Given this list of marker genes LSMEM1, SKA1, HYCC1, SSRP1, EOMES, SLC44A5, DCUN1D5, BCAM, PATE4, FOXJ3, ARL17A, TMEM260, JPH1, RORA, GSK3B, TRIM23, EN2, FAM107A, CCL28, RPTN, GIT2, NPY2R, GPM6A, RPRD1A, BBS10, GON4L, IKBKB, FOXN3, WSB2, BAG1 (BAG cochaperone 1), NFE2L2, TNS3, TAS2R14, NOVA2, WNK3, ZKSCAN8 (NCBI Gene Id 7745), ARIH1, TRPC4AP, ASPA, CNTFR, PLAG1, MST1L, FGB, NDOR1, GARRE1, ADGRL1, TEF, OSBPL10, here is a description of the gene set: Genes predicted to be targets of miRBase v22 microRNA hsa-miR-28-5p in miRDB v6.0 with MirTarget v4 prediction scores > 80 (high confidence targets). studied in species Homo sapiens Human Gene Set: MIR28_5P from publication Chen Y, Wang X (PMID 31504780)